The following is a description of a gene set: Mouse Gene Set: MARTORIATI_MDM4_TARGETS_NEUROEPITHELIUM_DN The p53 tumour suppressor functions as a transcriptional activator, and several p53-inducible genes that play a critical proapoptotic role have been described. Moreover, p53 regulates the expression of various proteins participating in autoregulatory feedback loops, including proteins that negatively control p53 stability (Mdm2 and Pirh2) or modulate stress-induced phosphorylation of p53 on Ser-46 (p53DINP1 or Wip1), a key event for p53-induced apoptosis. Here, we describe a new systematic analysis of p53 targets using oligonucleotide chips, and report the identification of dapk1 as a novel p53 target. We demonstrate that dapk1 mRNA levels increase in a p53-dependent manner in various cellular settings. Both human and mouse dapk1 genomic loci contain DNA sequences that bind p53 in vitro and in vivo. Since dapk1 encodes a serine/threonine kinase previously shown to suppress oncogene-induced transformation by activating a p19ARF/p53-dependent apoptotic checkpoint, our results suggest that Dapk1 participates in a new positive feedback loop controlling p53 activation and apoptosis. Genes down-regulated in apoptotic tissues (neuroepithelium) after MDM4 knockout. species: Mus musculus from publication Martoriati A, Doumont G, Alcalay M, Bellefroid E, Pelicci PG, Marine JC (PMID 15608685), and this is the list of marker genes: Ago1, Sgk3, Nhlh2, Cxcl13, Cnr1, Gpm6b, Ppp1r17, Rnd2, Cdk5r1 (cyclin dependent kinase 5, regulatory subunit 1), Ripply3, Insig1, Neurod1, Ctsc, Myb, Dlx6os1, Cfl2, Csf2rb, Fos, Zranb1, Csf1r, Oxct1, Hemgn, Eny2, D930028M14Rik, Tcaf1, Trp53inp2, Cx3cr1, Rem2, Map2, Jakmip2 (NCBI Gene Id 76217), Mir9-2hg, Mrc1, Gdap1, Duxbl1, Syt11, Rspo2, Nsg1, C1qtnf3, Rnh1, Brinp1, Elavl4, Rtn1, Foxg1, Maf, Neurog1, Dbx1, Stx3, Rgs4, Xist, Tbr1 (T-box brain transcription factor 1), Hsd17b11, Irf2bpl, Fmn2, Dach1, Fabp7, Pknox1, Tal2, Erdr1, Hand2, Rbl1, Dmrta2, Zcchc18, Mdm4, Jam2, Scrn1, Cd53, 6330403K07Rik, Scg3 (secretogranin III), Mtcl3, 2900060B14Rik, Mir100hg, Mturn, Cadps, Slc4a5, Kif21a, Slc17a6, Pkia, Ascl1, Fyn, Ermap, Frmd5, Cacng4, Rapgef5, D430019H16Rik, Pdgfra, Myt1, Neurod4, Cnmd, Cadm4, Atat1, Ina, Mapk10, Hdac9, Scg5, Coro1a, Pcdh9, Fstl5, Mir9-3hg, Scara3, Ttyh1, Igfbp5, Gfra1, Satb1, Kcna5, Zmat1, Ubxn2a, Ednrb, Cd1d1, Stmn2, Dcx (doublecortin), Elavl2, Prmt8, Mpped2, Elavl3, Pgm2l1, Apc2, Bhlhe22, Rhbdl3, Tal1, Tspyl4, Stmn3, Gsx1, Acss1, Adgrg1, C1qb, Grem2, Pea15a, Aldh1a1, St8sia4, Skor1, Vcam1, Eomes, Zbtb18, Itgb8, Lrrn1, Igfbpl1, Tyrobp, Hpgd, Arcn1, Sanbr, Tlcd4, Brsk2, Megf9, Spast, Egfl6, Abcd2, 1810037I17Rik, Pak1, Ly86 (NCBI Gene Id 17084), Tmem26, Kat2b, F13a1 (coagulation factor XIII, A1 subunit), Plcxd2, Lst1, Pou3f4, Id4, Bcl11a, Nol4, Rufy3, Shox2, Uncx, Nap1l2 (NCBI Gene Id 17954), Fgd4, Parp9, Nudt21, Ncan, Rnf182, Dlx5